The following is a description of a gene set: Human Gene Set: CCCNNGGGAR_OLF1_01 Genes having at least one occurrence of the highly conserved motif M130 CCCNNGGGAR in the regions spanning 4 kb centered on their transcription starting sites. This matches the EBF2 transcription factor binding site V$OLF1_01 (v7.4 TRANSFAC). studied in species Homo sapiens from publication Xie X, Lu J, Kulbokas EJ, Golub TR, Mootha V, Lindblad-Toh K, Lander ES, Kellis M (PMID 15735639) Comprehensive identification of all functional elements encoded in the human genome is a fundamental need in biomedical research. Here, we present a comparative analysis of the human, mouse, rat and dog genomes to create a systematic catalogue of common regulatory motifs in promoters and 3' untranslated regions (3' UTRs). The promoter analysis yields 174 candidate motifs, including most previously known transcription-factor binding sites and 105 new motifs. The 3'-UTR analysis yields 106 motifs likely to be involved in post-transcriptional regulation. Nearly one-half are associated with microRNAs (miRNAs), leading to the discovery of many new miRNA genes and their likely target genes. Our results suggest that previous estimates of the number of human miRNA genes were low, and that miRNAs regulate at least 20% of human genes. The overall results provide a systematic view of gene regulation in the human, which will be refined as additional mammalian genomes become available., and this is the list of marker genes: NF2, LPP, HBEGF, ARID1A, ZEB2, LRRC20, KDM3B, SPPL2C, TPM1, TXLNG, ABI3, SEPTIN9, P4HTM, CHRDL1, NR2E1 (nuclear receptor subfamily 2 group E member 1), THRA, TRMT112, C1orf21, PTMS, MAGED2, SGK2, PLEKHA6, HOXA6, FKBP2, UNG, AKAP12, LRRTM3, AAMP, PLAG1 (NCBI Gene Id 7996), NDUFS2, ZFAND3, UPF3B, CYTH3, DPF1, SORBS3, ADAMTSL2, MEIS2, ESAM, PSME3, FERMT3, PDGFC, COL18A1, FSTL3, ADAMTS4, PARP2, POGK, SPATC1L, KMT2A, UQCC2, PATZ1, TNIP1, RHOQ, IL4I1 (interleukin 4 induced 1), SLC25A14, DPYSL5, TMEM187 (NCBI Gene Id 8269), STC2, C6orf62, STIM2, MAGEL2, RAB10, EPHB3, SCG3, ARL4C, ENPP2, SLC9A6, ELL2, CLVS1, ERC1, COL11A2, DLL4, NCDN, TBX21, CHD5, SFRP2, PRRX1, UBE2N, HEBP2, OPCML, CD248, CA7, CA10, BAHD1, PPM1N, ZBTB9, DUSP4, TOM1L1, GCNT2, LRIT3, AIFM3 (NCBI Gene Id 150209), HOXA11, CACNA1I (NCBI Gene Id 8911), KDM4A, SNX13, COL23A1, EPN3, RNF44, FAXC, HIC2, CLDN15, NUP62, PCBP4, DTX3, TRAF4, FCHSD2, SPIB, MAG, PCGF2, HR, ADGRB2, SBF2, GIPC3, RORC, REEP6, ECM2, SH3TC2, ST8SIA4, PIGW, GREM1, C1QL1, KLF10, MECOM (MDS1 and EVI1 complex locus), MTMR14, CD72, ICA1, SOWAHA, PPFIA2, BANP, PTHLH, ARMCX3, FBXO11, ETV6, C2orf69, ROBO3, HOXC10, C2CD2L, EGR1 (early growth response 1), ZNF232, CA2, NDFIP1, STAG2 (STAG2 cohesin complex component), CYB561D1, ADRB1, ZPR1, TIAM1, ADCY4, GRIK3, HS3ST4, CDON, ETV4, REPIN1, PACSIN1, KIF19, HS3ST2, MDGA1, SLC25A28, BMP4, RNF43, NFKBID, ATP2B3 (ATPase plasma membrane Ca2+ transporting 3), MADCAM1, C1QTNF1, IGF2R, LUC7L2, SP4, LIMK2, ELK3, PRRC2A, NEUROD2, MAP4, PTAFR, LRP1, BAZ2A, YRDC, APH1A, LRP8, SMARCE1, CDC20B, CLEC18C (NCBI Gene Id 283971), TLNRD1, GRIN2D, GPM6B, GRK5, MGAT4C, PRR14, MAPKAP1, DDR1, PRDM10, MTX1, LIN28A, CTDSPL2, SSH2, PCYT1B, FLT1, HAPSTR1, RHOG, RAPGEFL1, TMEM132E-DT, VASN, CNTN2, JARID2, SEMA3G, UBTF, NFKBIA, FGF11, TRIM55, PNKD, DLX1, ATF5, GIT1, DNAJC22, STARD13 (NCBI Gene Id 90627), TFIP11, EFCAB5, UBAP1, GNB2, GNGT2, PDZRN4, STEAP3, KCND1, AXL, COA3, NEO1, GNAO1, ABR, PIAS1, CHL1, WDR13 (NCBI Gene Id 64743), OPA3 (outer mitochondrial membrane lipid metabolism regulator OPA3), TNNT3, TMEM132E, TMEM182, SEL1L3, POU2AF1, DMPK, CD79B, PAX2, CKM, PRPF38B, FBXL19, SDCCAG8, PRDM12, C1orf122, TMEM255A, SP3, ZNF436-AS1, SYTL2, EFS, EPB41L4B, CHAT, DUSP22, GASK1B, CBX6, TFR2, DAB1, MTSS1, TRIM29, FCRLA, TNS2, SLC30A5, MYO19, MPST, GJC1, NRN1L, TBC1D10B, FBXL19-AS1, H1-0, TTYH1, TST, CNTD1, PPP3CB, THBS3, VASP, SMPD3, ZNF436, ROGDI, ALKBH6, MMP1, ICAM1, PDAP1, GGNBP2, PTMA, SNCB, WNT7B, ALOX12B, ANXA9, TNKS1BP1, CCDC8, ATP1A1, APBA1, TRIM8, ZNF593, GRIK1, FOXJ2, RBM10, PLPP5, PLXDC2 (NCBI Gene Id 84898), BCOR, MLLT6, VAT1, HPCA, H3-3B, ST3GAL2, CHCHD7, BCL9L, LHX2, LRFN3, LASP1, ADCYAP1, NTN5, IL11, HCST, RGS3, RUNX1T1, MYOZ1, TMEM59L, GRM7 (glutamate metabotropic receptor 7), TRIB2, CALM1, RAB39A, ZDHHC14, ZNF575, C1orf54, ELAVL3, GLI1, SLC41A1